The following is a description of a gene set: species: Homo sapiens part of: Signaling by CTNNB1 phospho-site mutants Reactome Pathway: CTNNB1 S37 mutants aren't phosphorylated S37 mutations of beta-catenin interfere with GSK3 phosphorylation and stabilize the protein, resulting in enhanced WNT pathway signaling. S37 mutations have been identified in cancers of the brain, liver, ovary and large intestine, among others., and this is the list of marker genes: PPP2R5B, PPP2CA, PPP2R5D, PPP2CB, PPP2R5C, PPP2R1B, APC, GSK3B, PPP2R1A, CTNNB1, AXIN1, CSNK1A1, PPP2R5E, AMER1, PPP2R5A